The following is a description of a gene set: The developmental process pertaining to the initial formation of a nephron tubule from unspecified parts. A nephron tubule is an epithelial tube that is part of the nephron, the functional part of the kidney. Mouse Gene Set: GOBP_NEPHRON_TUBULE_FORMATION studied in species Mus musculus, and this is the list of marker genes: Pax2, Mir217, Irx1, Irx3, Osr1, Ctnnb1, Pax8, Six1, Nog, Hnf1b, Sox8, Gata3, Mir216b, Hs2st1, Grem1, Sox9, Six4, Wnt9b, Irx2, Hes5, Wnt6, Mir216a, Gdnf